The following is a description of a gene set: studied in species Homo sapiens Human Gene Set: chr19q11, and this is the list of marker genes: ENSG00000266977, ERVK-28, LINC02987, ENSG00000297628, LINC00662, VN1R95P, SLC25A1P5